The following is a description of a gene set: species: Mus musculus A multiprotein complex that forms a strong mechanical link between the cytoskeleton and extracellular matrix; typical of, but not confined to, muscle cells. The complex is composed of transmembrane, cytoplasmic, and extracellular proteins, including dystrophin, sarcoglycans, dystroglycan, dystrobrevins, syntrophins, sarcospan, caveolin-3, and NO synthase. Mouse Gene Set: GOCC_DYSTROPHIN_ASSOCIATED_GLYCOPROTEIN_COMPLEX, and this is the list of marker genes: Cav3 (caveolin 3), Sgce, Krt19, Sntb2, Snta1, Sgcb, Utrn, Sntg1, Sgcg, Sgcz, Dtna, Dmd, Sntb1, Sspn, Sgcd, Krt8, Dag1, Pgm5, Sgca, Sntg2